Given this list of marker genes HSF1, PLPPR2, UQCR10, MSX1, NAPSA, RRAGA, LIMA1, H3C7, SRSF7, CCRL2, HMX1, PTPN22, G0S2, SVIL, SH2D1B, SLC30A5, S100A4, CASP8AP2, NICN1, FOSB, FKBP4, CNPY2, NPM3, CREBBP, KLF2, ANKRD33B, ELOVL5, NHERF1, OCIAD1, GNG10, PPP6C (NCBI Gene Id 96749), RGS3, PPAN, DDX3X, SMIM11, FHDC1, DDX5 (NCBI Gene Id 1655), XRN1, PAWR, OPRL1, NOP16, ACAD9, FKBP3, ST6GAL1, SEMA3F, JUN, TMEM14C, DUSP6, PRKDC, JUNB, LSM2, PPP1R21, RAB3IL1, RRP9, BRCA2 (NCBI Gene Id 82716), TSPAN4, ROBO3, PTGIS, EML5, RPS6, DHX30, MSI1, ATP1A1, IFI27, IL10RB, CLK2 (NCBI Gene Id 1196), TOB1, DDOST, MRFAP1L1, RRM1, TMEM115, CD244, CHTF8, CEBPD, KLF6, RPL3, VPS29 (NCBI Gene Id 51699), PTS, FABP4, GJB2, SAFB, DMRTB1, SRSF6 (serine and arginine rich splicing factor 6), THBD, NT5C3B, TAF1C, G3BP1, SMARCD2, MLLT3, GUCY2D, SERP1, IPO5, DHRS7B, STAT6, ABCC3, CXCR2 (C-X-C motif chemokine receptor 2), LGMN, MED24, EGR1 (NCBI Gene Id 1958), MRPS15, PRIM1, EEF2K, ACAA2, PIK3C2G, MAFB, CSTF2, SMARCA5, ZFP36, CSF3R, GSK3A, RASSF5, ARSA, SRSF5, SUMO3, DECR1, ADRB2, CYTIP (cytohesin 1 interacting protein), ZFP36L2, MYCL, ITLN1, KLF4, STRAP, CAVIN2 (caveolae associated protein 2), GALNT1, RBM39, OSBPL9, RNF103, CPQ, SUCLG2, CDK11B, SCOC, DAGLB, EWSR1, DTD1, AXL, RAP2A, PFDN2, SH3GL1, NDFIP1, SLC16A7, ADK, KITLG, ZMYND11, GGCX, ADA, ITPR1, ICAM2, IARS1, SNX5, CCND2, RPN2, TPGS2, TMEM223, LMNB1, KIT, GATM, CEBPZ, FGL2, IGF1R, SERPINB6, MAPRE2, CDIPT, UGCG, H1-1, ADAMDEC1, CCND1 (cyclin D1), ADCY3, CBX6, SLC15A2, POLR1A, SLC35C2, SELPLG, CHMP1B, ZNF706, IER2, PTK2, SLC12A2, DUSP1, METTL3, ATP13A3, SRSF2, RALB, RGL2, NPL, HIRA, VRK1, MRC1, ENTPD1, MAPRE1, BRD4, PCNA, ETFB, DDR1, TIMELESS, NID2, LAMA1, GGT5, POLA2, ARHGAP45, ST8SIA1, here is a description of the gene set: Human Gene Set: GSE12392_CD8A_POS_VS_NEG_SPLEEN_IFNB_KO_DC_DN from publication Zietara N, Łyszkiewicz M, Gekara N, Puchałka J, Dos Santos VA, Hunt CR, Pandita TK, Lienenklaus S, Weiss S (PMID 19581626) species: Homo sapiens Genes down-regulated in splenic dendritic cells from IFNB1 knockout mice: CD8A+ versus CD8A- populations. Type I Interferons encompasses a large family of closely related cytokines comprising of at least 13 IFN-α isotypes and single IFN-β. Both IFN-α and IFN-β exert their activity through a common receptor IFNAR. Type I Interferons have broad regulatory effects and various subtypes of dendritic cells are influenced by this cytokines. In our study we asked question whether the low, constitutive levels of type I Interferons produced under steady state conditions are important for proper function of splenic conventional dendritic cells.